The following is a description of a gene set: Human Gene Set: HP_DEPRESSED_NASAL_RIDGE Lack of prominence of the nose resulting from a posteriorly-placed nasal ridge. studied in species Homo sapiens Depressed nasal ridge, and this is the list of marker genes: SKIC3, TCTN3, PDE4D, UBE4B, PAX7 (paired box 7), SOX9, PEPD, CC2D2A, TCTN1, ABCA12, BMPER, MKS1 (NCBI Gene Id 54903), CASZ1, TFAP2B, PKHD1, GJA1, TCTN2, PSAT1, TMEM231, GABRD, GLI2, CEP290, FGF20, TMEM107, LBR, TWIST2, FOXA2, RERE, FGFR1, SHH, CSPP1, RMRP, HSPG2, PAX3, PIGL, KDM6A (NCBI Gene Id 7403), FGF8, ATRX, GH1, MEGF8, B9D1, KDF1, GMNN, RAB23, AASS, CHRND, CEP57, GLB1, MMP23B, TMEM67, TXNDC15, SIX3, NALCN, EDAR, EDA2R, DLL1, RET, WNT9B, SPEN, PEX12, MN1, BUB3, RPS19, CREBBP, RPGRIP1, RPGRIP1L, SLC35C1, BMP4, CRIPTO, GREB1L, PRMT7, TRAF6, CNOT3, KCNAB2, PRDM16, GHR, ARSL, STAG2, LMBR1, MAN2B1, MYH3, GAS1, DZIP1L, PTPN11, FBXO11, BUB1, LHX4, TGIF1, STIL, TBX1, DISP1, HDAC6, LUZP1 (NCBI Gene Id 7798), EDA, POU1F1, PUS1, EFNB1, ALX4, PROP1, PDPN, CHRNG, NODAL, FAM20C, TRIP13, SKI, ITGA8, SNAP29, PRKCZ, DDR2, SOX3, TMEM216, OTX2, FOXH1, MBD5, EDARADD, CHRNA1, PHGDH, PLCH1 (phospholipase C eta 1), TMEM237, B9D2, CDON, HESX1 (HESX homeobox 1), BUB1B, GLI3, SMC1A, PRKAR1A, HSPA9, GFRA1, KMT2D, PTCH1, ZIC2